Given this list of marker genes Arsa, Sumf1, Arsj, Arsi (NCBI Gene Id 545260), Arsg, Sts, Sumf2, here is a description of the gene set: electronically inferred by orthology from the curated human pathway part of: Gamma carboxylation, hypusinylation, hydroxylation, and arylsulfatase activation studied in species Mus musculus This event has been computationally inferred from an event that has been demonstrated in another species.<p>The inference is based on the homology mapping from PANTHER. Briefly, reactions for which all involved PhysicalEntities (in input, output and catalyst) have a mapped orthologue/paralogue (for complexes at least 75% of components must have a mapping) are inferred to the other species. Reactome Pathway: The activation of arylsulfatases